Given this list of marker genes KITLG (KIT ligand), DVL2, ACHE, MFAP5, JUND, APLNR, MAPK10, GRM5, SOCS1 (NCBI Gene Id 8651), FRZB, EFNB1, ARID4A, IGF1R, SSTR4, PRKAG3, FZD2, SOCS3, ARID5A, MEF2B, RXRA (retinoid X receptor alpha), JAK3, CEBPB, MYL2, NUMB, JMJD7-PLA2G4B, MYF5, FOXM1, STAT5A, IL12RB2, NTF4, CLU, CSH2, MYOG, STAT1, ESR1, PRKAA1, here is a description of the gene set: from publication Sakai Y, Honda M, Fujinaga H, Tatsumi I, Mizukoshi E, Nakamoto Y, Kaneko S (PMID 19074895) Hepatocellular carcinoma (HCC) is frequently associated with infiltrating mononuclear inflammatory cells. We performed laser capture microdissection of HCC-infiltrating and noncancerous liver-infiltrating mononuclear inflammatory cells in patients with chronic hepatitis C (CH-C) and examined gene expression profiles. HCC-infiltrating mononuclear inflammatory cells had an expression profile distinct from noncancerous liver-infiltrating mononuclear inflammatory cells; they differed with regard to genes involved in biological processes, such as antigen presentation, ubiquitin-proteasomal proteolysis, and responses to hypoxia and oxidative stress. Immunohistochemical analysis and gene expression databases suggested that the up-regulated genes involved macrophages and Th1 and Th2 CD4 cells. We next examined the gene expression profile of peripheral blood mononuclear cells (PBMC) obtained from CH-C patients with or without HCC. The expression profiles of PBMCs from patients with HCC differed significantly from those of patients without HCC (P < 0.0005). Many of the up-regulated genes in HCC-infiltrating mononuclear inflammatory cells were also differentially expressed by PBMCs of HCC patients. Analysis of the commonly up-regulated or down-regulated genes in HCC-infiltrating mononuclear inflammatory cells and PBMCs of HCC patients showed networks of nucleophosmin, SMAD3, and proliferating cell nuclear antigen that are involved with redox status, the cell cycle, and the proteasome system, along with immunologic genes, suggesting regulation of anticancer immunity. Thus, exploring the gene expression profile of PBMCs may be a surrogate approach for the assessment of local HCC-infiltrating mononuclear inflammatory cells. species: Homo sapiens Human Gene Set: SAKAI_CHRONIC_HEPATITIS_VS_LIVER_CANCER_DN Selected genes down-regulated in peripheral blood monocytes (PBMC) of patients with hepatocellular carcinoma (HCC) compared to those with chronic hepatitis.